The following is a description of a gene set: Any process that activates or increases the frequency, rate or extent of cell death of neurons by apoptotic process. studied in species Mus musculus Mouse Gene Set: GOBP_POSITIVE_REGULATION_OF_NEURON_APOPTOTIC_PROCESS, and this is the list of marker genes: Atf4, Ppp2r2b, Egr1, Casp12, Cdc34b, Grn, Ube2m, Nf1, Casp14, Casp9, Il1b, Mapk8, Foxo3, Il18, Casp2, Atm, Mybl2, Map2k4, Tgfb2, Atf2, Casp8, Ptprf, Pmaip1, Cflar, Mtor, Casp6, Jun, Pak3, Epha7, Gsk3a, Map3k11, Mcl1, Fgfr3, Hdac4, Egln1 (NCBI Gene Id 66006), Fis1, Gch1, Fbxw7, Rhoa, Bace1, Agrn (agrin, NCBI Gene Id 381587), Pin1, Cdk5r1, Htr2a, Pawr, Prnp, Adcy10, Fasl, Trp53, Pitx3, Ccr5, Map2k7, Ccl3, Gsk3b, Hrk, Bdnf, Nqo1, Cdk5, Casp4, Tfap2a, Ascl1, Lcn2, Traf7, Cdc42, Ncf2, Fas, Ripk1, Itga1, Phb1, App, Tfap2b, St8sia2, Nr3c1, Mmp2, Nfatc4, Casp3, Hdac3, Ctnnb1, Kcnma1, Tnfrsf1a, Aimp2, Bax, Srpk2, Musk, Bcl2l11, Optn, Cdc34, Pin1rt1, Aifm1, Casp7, Grik2, Bbc3, Ager, Tnf, Grik5, Rapsn, Ddit3, Pcsk9, Nqo2, Abl1, Pou4f1, Nox1, Myb, Nupr1